The following is a description of a gene set: studied in species Homo sapiens Human Gene Set: AGGTGCA_MIR500 Genes having at least one occurence of the motif AGGTGCA in their 3' untranslated region. The motif represents putative target (that is, seed match) of human mature miRNA hsa-miR-500 (v7.1 miRBase)., and this is the list of marker genes: ADAMTSL3, NBEA, HSALR1, SHPRH, SPEM2, DRD1, ZNF711, KPNA3, FNDC3B, E2F3, OGT, TSSK2, PURB, WAPL, DCTN4, UBE2D3, LBP, CA10, FOXG1, MATR3, HNRNPA0, EPB41L1, RAB14, YIPF6, DLG3, KLF9 (NCBI Gene Id 687), CCDC6, TSHZ3, ZRANB2, CELSR3, PPP3CC, ABCC4, NFAT5, SLC4A7, THAP11, GPM6A, NALF2, CREB1, RAI2, PDZD2, DDX3X, SYT8, PATZ1, ING4, IVNS1ABP, EGLN2, SEC24C, CHRD, RTN4RL1, LRRC14, TNRC6B, HIPK1, RBMS1, KBTBD2, KCNK10, GABRB3, OSBPL10, CIT, RAB21, FIGN, CCDC106, PDS5B, PRKCE, PHOX2B, TP53INP2, SP8, HSPA14, POFUT1, PPP4R1, LIN54, RNF40, DDX3Y, ZNF236, LRRTM3, ABTB3, HLF, FBXW7, NRF1, MYNN, PLPPR4, CAMK4 (NCBI Gene Id 814), TIMM8A, SLC25A26, TBX2, B4GALNT3, NCOA1, PPP2R5E, RNF38, CACNB1, SOCS2, NHP2, MACIR, ATL1, PLXDC2, CUX1, ESRRG, SORCS1, ANKRD13A